Given this list of marker genes CDKN2B, CDKN2C, TBX1, PRKAR1A, PLXND1, GK, ABCD1, CDKN1A (cyclin dependent kinase inhibitor 1A), MEN1 (NCBI Gene Id 4221), PDE11A, CDKN1B, NKX2-6, here is a description of the gene set: Adrenocortical abnormality Human Gene Set: HP_ADRENOCORTICAL_ABNORMALITY studied in species Homo sapiens